The following is a description of a gene set: The functional roles of neutral lipids in the lung are poorly understood. However, blocking cholesteryl ester and triglyceride metabolism in lysosomal acid lipase gene knockout mice (lal-/-) results in severe pathogenic phenotypes in the lung, including massive neutrophil infiltration, foamy macrophage accumulation, unwanted cell growth, and emphysema. To elucidate the mechanism underlining these pathologies, we performed Affymetrix GeneChip microarray analysis of 1-, 3-, and 6-month-old mice and identified aberrant gene expression that progressed with age. Among changed genes, matrix metalloproteinase (MMP)-12, apoptosis inhibitor 6 (Api-6), erythroblast transformation-specific domain (Ets) transcription factor family member Spi-C, and oncogene MafB were increased 100-, 70-, 40-, and 10-fold, respectively, in lal-/- lungs versus the wild-type lungs. The pathogenic increases of these molecules occurred primarily in alveolar type II epithelial cells. Transcriptional activities of the MMP-12 and Api-6 promoters were stimulated by Spi-C or MafB in respiratory epithelial cells. Treatment with 9-hydroxyoctadecanoic acids and ciglitazone significantly rescued lal-/- pulmonary inflammation and aberrant gene expression. In addition, both compounds as well as peroxisome proliferator-activated receptor gamma inhibited MMP-12 and Api-6 promoter activities. These data suggest that inflammation-triggered cell growth and emphysema during lysosomal acid lipase deficiency are partially caused by peroxisome proliferator-activated receptor-gamma inactivation. Human Gene Set: LIAN_LIPA_TARGETS_3M studied in species Mus musculus from publication Lian X, Yan C, Qin Y, Knox L, Li T, Du H (PMID 16127159) Genes up-regulated at 3 months of age in lungs from LIPA knockout mice, which display pulmonary pathology., and this is the list of marker genes: TNFAIP2, CAMP, PLA2G7, MMP8, GPNMB, MMP19, ACOD1, DNMT3A, CSTA, C1QB, CD68 (CD68 molecule), TLR7, MAFB, C1QC, FKBP5, CTSB, IGSF6, CD244 (NCBI Gene Id 51744), SNX6, AAR2, CD5L, SEMA7A, FCER1G, CXCL2, XIST, MSR1, SLFN12, CCR1, LY9, ATP6V0D2, SPIC, MPEG1, ACP5, FCGR2A, MS4A7, NEU1, CLEC4D, MYO5A, LILRA4, HMOX1, ADGRE4P, IL1R2, APOBEC1, LILRB1, SLC11A1, MARCO, TREM2, STEAP4, C3AR1, CLEC6A, RGS1, CLEC4E, GDF15, C1QA, SLC15A3, MS4A6A, CFP, SLC40A1, FABP7, S100A9, KLRB1, FCGR2B, MMP12, UTRN